The following is a description of a gene set: Enables the transfer of a specific substance or related group of substances from the inside of the cell to the outside of the cell across a membrane. studied in species Mus musculus Mouse Gene Set: GOMF_EFFLUX_TRANSMEMBRANE_TRANSPORTER_ACTIVITY, and this is the list of marker genes: Abcc1, Abcb5 (NCBI Gene Id 77706), Slc22a2, Xpr1, Slc30a5, Abcc4, Slc17a3, Abcg2, Slc39a9, Gja1, Abcb1a, Abcg3, Abcc5, Slc26a6, Abcb1b, Slc27a1, Abcb6, Slc29a4